Given this list of marker genes Zfp131, Stag2, Iqschfp, Wdr5, Plpp3, Zfp1009, Plxna1, Fam171a2, Zc3h7b, Rictor, Git1, Tmem158, Arl4c, Zcchc3, D5Ertd579e, Tm9sf4, Cldn2, Btg1, Frg1, Jchain, Tgfb3, Fndc5, Tmem68, Eda2r, Nfat5, Mecp2, Rasip1, Rasgef1b, Lhfpl2, Atf2, Bsn, Gm14308, Hoxb5, Cdyl2, Relch, Ppargc1a, 5730507C01Rik, Zfp931, Cers6, Hipk3, Tle4, Ino80d, Kat7, Gm6710, Sobp, Fgf9, Ndst1, Psen1, Trim33, Pde1c, D3Ertd751e, Krbox5, Slc5a3, Kmt5b, Sucla2, Atxn7l3b, Ppp2r5c, Tab2, Zc3h6, Gm14434, Fbxo33, Glrp1, Atl2, Ldaf1, Suco, Zfp781b, Mvb12b, Pcdh17, Cldn1, Slain2 (NCBI Gene Id 75991), Ythdf1 (YTH N6-methyladenosine RNA binding protein 1), Zfp966 (NCBI Gene Id 667962), Acnat1, Pcdh8, Arhgap17, Rbfox2, Pik3r3, Acvr2b, Zdhhc17 (NCBI Gene Id 320150), Skil (NCBI Gene Id 71615), Pramel30, Notch2, Crebzf, Sh3pxd2b, Pfkfb3, Sub1, Serpinb6c, Kctd11, Dnm1, Gpr149, Epb41l4a, S100a3, Ap1g1, Gm14325, Nono, 1700031F05Rik, Sirt1, Stx3, Ccdc160, Txlng, Lgalsl, Lypla1, Pramel14, Lmbr1, Pdpk1, P2ry1, Zfp970 (zinc finger protein 970), Sva, Wdfy1, Hsbp1, Nr1d2, Dip2c, D630003M21Rik, Pld5, Zfp967, Ubap2l, Naa50 (N(alpha)-acetyltransferase 50, NatE catalytic subunit), Rc3h1, Klhl12, Ankrd28, 2210418O10Rik (NCBI Gene Id 620804), Tmem52b, Kif5c, Gprin3, Casd1 (CAS1 domain containing 1), Arl6ip5, Anapc1 (anaphase promoting complex subunit 1), Gm4724, Tra2a, Erich4, Gm14296, Peak1, Adam10, Rbm7, Gm3604, Homer1, Arhgef7, Cry1, Olig3, Gm14326, Tmppe, Ugt2b35, Cntn6, Ubqln2 (ubiquilin 2), here is a description of the gene set: Mouse Gene Set: MIR_140_3P species: Mus musculus from publication Chen Y, Wang X (PMID 31504780) Genes predicted to be targets of miRBase v22 microRNA mmu_miR_140_3p in miRDB v6.0 with MirTarget v4 prediction scores > 80 (high confidence targets).